Given this list of marker genes BACH2, ACHE, STIM1, NT5DC1, ASH1L, KLHL42, here is a description of the gene set: species: Homo sapiens Genes down-regulated in ovarian epithelial cells in response to dihydrotestosterone (DHT). from publication Motamed-Khorasani A, Jurisica I, Letarte M, Shaw PA, Parkes RK, Zhang X, Evangelou A, Rosen B, Murphy KJ, Brown TJ (PMID 16832351) Human Gene Set: MOTAMED_RESPONSE_TO_ANDROGEN_DN Epidemiological studies have implicated androgens in the etiology and progression of epithelial ovarian cancer. We previously reported that some androgen responses were dysregulated in malignant ovarian epithelial cells relative to control, non-malignant ovarian surface epithelial (OSE) cells. Moreover, dysregulated androgen responses were observed in OSE cells derived from patients with germline BRCA-1 or -2 mutations (OSEb), which account for the majority of familial ovarian cancer predisposition, and such altered responses may be involved in ovarian carcinogenesis or progression. In the present study, gene expression profiling using cDNA microarrays identified genes differentially expressed in response to continuous androgen exposure in OSEb cells and ovarian cancer cells as compared to OSE cells derived from control patients. A subset of these differentially affected genes was selected and verified by quantitative real-time reverse transcription-polymerase chain reaction. Six of the gene products mapped to the OPHID protein-protein interaction database, and five were networked within two interacting partners. Basic leucine zipper transcription factor 2 (BACH2) and acetylcholinesterase (ACHE), which were upregulated by androgen in OSEb cells relative to OSE cells, were further investigated using an ovarian cancer tissue microarray from a separate set of 149 clinical samples. Both cytoplasmic ACHE and BACH2 immunostaining were significantly increased in ovarian cancer relative to benign cases. High levels of cytoplasmic ACHE staining correlated with decreased survival, whereas nuclear BACH2 staining correlated with decreased time to disease recurrence. The finding that products of genes differentially responsive to androgen in OSEb cells may predict survival and disease progression supports a role for altered androgen effects in ovarian cancer. In addition to BACH2 and ACHE, this study highlights a set of potentially functionally related genes for further investigation in ovarian cancer.